Given this list of marker genes HIF1A, PBX1, BCL6, CNOT2, RUNX3, STK36, WIZ, NEK6, HDAC5, RUNX1, PHF1, THAP7, PER1 (period circadian regulator 1), SMAD4, LEF1, FAM89B, LCOR, EHMT2, STAT1, HDGF, HDAC6, ETS1 (NCBI Gene Id 2113), EZH2, CTBP1, USP11, PHF12, SUZ12, ZBTB16, CTBP2, ELOC, TRAPPC2B, HDAC1, CTNNB1, NR1D1, EED, SIX3, HDAC3, SMAD3, TCF7L2, ZBTB7A, ESR1, MTF2, TP73, PER2, ZNF644, ENO1, ELOB, RORA, EHMT1, HES1, PER3, here is a description of the gene set: Human Gene Set: GOMF_TRANSCRIPTION_COREPRESSOR_BINDING Binding to a transcription corepressor, a protein involved in negative regulation of transcription via protein-protein interactions with transcription factors and other proteins that negatively regulate transcription. Transcription corepressors do not bind DNA directly, but rather mediate protein-protein interactions between repressing transcription factors and the basal transcription machinery. studied in species Homo sapiens